Given this list of marker genes FERMT1, SHCBP1L, KDM1A, PCDHAC1, GNPTAB, NCKAP1L (NCK associated protein 1 like), TBC1D25, NIPBL, TTC28, GJB4, JADE2, NSD1 (NCBI Gene Id 6797), ZBTB25, PCDHA6, PPARD, PPP2R2D, PCDHA13, CACNG2, PCDHA2, LPGAT1 (NCBI Gene Id 9926), DIRAS2, ZNF791, BBIP1, TAB2, PCDHA5, ARHGAP24, XPO5, PCDHA3, PGA4, SMURF1, ERI2 (NCBI Gene Id 730570), PCDHA1, MLLT10, ACLY, GRIN1, LEPROT, KRTAP4-11, RASL12, ZNF516, TBC1D2B, NRM, SMCR8, FBXW7, COL27A1, CASP2, GNS, RAP1GDS1, CLDN2, YWHAE, PCDHA11, PCDHA9, BMP8A, MARCKSL1, KCNAB2, SH3TC2, PCDHA4, SF3A2, WBP11, PCDHA7, UCK1, RUNX2 (RUNX family transcription factor 2), ZNF607, DNAAF9, PGA3, MRI1, DTX1, PPP6R3, TRIM62, PCDHA10, DEPDC1 (DEP domain containing 1), PCSK5, ADAMTS15, NACC2, HOXA1, PREPL, HYCC2 (hyccin PI4KA lipid kinase complex subunit 2), PGA5, PCDHA8, SMIM21, AP1M1, SZRD1, CARD16, ARHGAP32, MBOAT2, EID1, AP1S1, PCDHA12, PCDHAC2, here is a description of the gene set: Genes predicted to be targets of miRBase v22 microRNA hsa-miR-194-3p in miRDB v6.0 with MirTarget v4 prediction scores > 80 (high confidence targets). from publication Chen Y, Wang X (PMID 31504780) Human Gene Set: MIR194_3P species: Homo sapiens